Given this list of marker genes CFAP276 (cilia and flagella associated protein 276), RPL10P9, SLC44A4 (solute carrier family 44 member 4), LINC02660, SIX1 (SIX homeobox 1), FOXJ1, CFAP57, CLIC6, TMC5, CAPS, CIMAP3, AGR2, CFAP95 (NCBI Gene Id 138255), MUC1, SCGB3A2, SFTPC, TTC23L, ZMYND10, ENSG00000231119, PIH1D2, LINC02455, DNAH9, DNAH5, TACSTD2, LINC01405, ELF3, FAM216B, ANKRD2, DEGS2, ZBBX, RSPH1, LINC01801, CP, SAXO2, WIF1, CRLF1, DNAH3, RXYLT1-AS1, CYP2W1, AGBL2, EFCAB12, IL20RA, MS4A8, SCGB1A1, CLXN, SFTPB, here is a description of the gene set: Human Gene Set: DESCARTES_FETAL_HEART_ELF3_AGBL2_POSITIVE_CELLS The gene expression program underlying the specification of human cell types is of fundamental interest. The study authors generated human cell atlases of gene expression and chromatin accessibility in fetal tissues. For gene expression, the study authors applied three-level combinatorial indexing to >110 samples representing 15 organs, ultimately profiling ~4 million single cells. The study authors leveraged the literature and other atlases to identify and annotate hundreds of cell types and subtypes, both within and across tissues. Our analyses focused on organ-specific specializations of broadly distributed cell types (such as blood, endothelial, and epithelial), sites of fetal erythropoiesis (which notably included the adrenal gland), and integration with mouse developmental atlases (such as conserved specification of blood cells). These data represent a rich resource for the exploration of in vivo human gene expression in diverse tissues and cell types. from publication Cao J, O'Day DR, Pliner HA, Kingsley PD, Deng M, Daza RM, Zager MA, Aldinger KA, Blecher-Gonen R, Zhang F, Spielmann M, Palis J, Doherty D, Steemers FJ, Glass IA, Trapnell C, Shendure J (PMID 33184181) Marker genes curated from the annotated cluster as represented in the Descartes Human Gene Expression During Development database. studied in species Homo sapiens